Given this list of marker genes MSH3, MSH2, here is a description of the gene set: Reactome Pathway: Defective Mismatch Repair Associated With MSH3 part of: Diseases of Mismatch Repair (MMR) species: Homo sapiens MSH3 forms a heterodimer with MSH2 to form the MSH3:MSH2 complex, part of the post-replicative DNA mismatch repair system. This complex initiates mismatch repair by binding to a mismatch and then forming a complex with MutL alpha heterodimer. This gene contains a polymorphic 9 bp tandem repeat sequence in the first exon. Defects in this gene are a cause of susceptibility to endometrial cancer.